The following is a description of a gene set: Catalysis of the transfer of ubiquitin to a histone H2A substrate. Human Gene Set: GOMF_HISTONE_H2A_UBIQUITIN_LIGASE_ACTIVITY studied in species Homo sapiens, and this is the list of marker genes: RNF168, PCGF5, BRCA1, BARD1, UBR2, PCGF3, TRIM37, RNF2